The following is a description of a gene set: Human Gene Set: GOBP_MEMBRANE_DOCKING studied in species Homo sapiens The initial attachment of a membrane or protein to a target membrane. Docking requires only that the proteins come close enough to interact and adhere., and this is the list of marker genes: ESYT2, STX8, RAB3IP, EXOC6B (exocyst complex component 6B), STX17, EXOC1, RAB7A, VPS11 (VPS11 core subunit of CORVET and HOPS complexes), STXBP1, CPLX2, RIMS3, STX6, CEP83, GNAO1, SNAP25, EXOC7, VAMP8, VTI1B, BVES, NDRG4, RALB, VPS18 (NCBI Gene Id 57617), PPFIA3, RAB8A, PLEK, PEX16, STX1B, ESYT3, VAPB, PACS2, CLN3, CFTR, AHCYL1, UNC13C (NCBI Gene Id 440279), ATP2A2, CAV2, GRAMD2A, STX7, PEX26, VAMP3, BLOC1S6, USO1, EZR, SNAP29, STX11, UNC13B, KCNB1, VMP1, CHP1, RABEPK, CEP290, ESYT1, STX10, VAPA, TPRG1L, YKT6, STX19, SYT1, EXOC6, STXBP3, EXOC2, STX3, STX5, STX2, ATG14, PDZD8, STX1A, RIMS2, STX4, STX16, EXOC8, UNC13A, VCAM1, TSNARE1, STX12, SNPH, EXOC3, RIMS1, MSN, CALM1, PSEN2, SNX3, EXOC4, STXBP2, ICAM1, SYTL2, ROCK1, EXOC5, SELENON